Given this list of marker genes RAB21, GNRHR, ADCY7, PDK3, DIP2B, MARCHF7, RIOK2, WDR76, TPMT, ZNF624, MTPN (NCBI Gene Id 94351), TMEM47, LRCH2, MARK3, SETBP1, SDR16C5, PDE7A, SOCS2, RCOR3, EPM2AIP1, CDH13, AK2, PACRGL, C8orf33, TFAP2B, NPY2R, NECAP1, TMEM43, PPFIA2, RPA1, EIF4E, KAAG1, FOXR2, TTC5, TMEM131, ZBTB20, ODAPH, BRWD3, MARCHF9, LIMS1, SMIM20, SMOC2, SCAF4, HS3ST3B1, SACS, XRCC2, ASPH, DYNC1I1, LRATD1, NR2C2, BBS12, PELI1, MKLN1, IL11, KICS2, FAHD1, KIAA1958, PAX8, EGR4, ZKSCAN1, MEI4, NUP54, ZMYM2, ZMYND11, CEP70, XKR6, SGIP1, NKAPD1, DIP2C, ERICH2, VPS45, CCNT2, SLC17A8, NR1D2, COL19A1, SUMO1, CRIM1, FAM3C, SAYSD1, PARP4, GBP1, CCER1, GOLGA7, ADD3, ANK3, AK5, NTRK1, GNPNAT1, DIO2, GABPB1, CARMIL1, ZNF592, FGD4, NLGN1, ENY2, SPICE1, SHANK2, ACTR3, UACA, ERCC6, YTHDF3, PTPRZ1, SATB1, RASSF6, SRSF1, BICRAL, CD47, SLC6A6, TMEM87B, ZEB2, TUBGCP3, TOR1AIP2, IBTK, TMEM273, PGM3, TRMT9B, HMGCS2, MARCHF5, RFX4, EPC1, CCDC34, RANBP3L, DPYD, PIKFYVE, HECW2, PLPBP, MTDH, CCDC14, CXXC4, MPI, PDE4D, ELK4, ELF2, ZNF503, POC5, ZNF33B, CACNA2D1, E2F3, CA13, FMNL2, BCAT1, STX16, MYBL1, PFN2, FSTL5 (follistatin like 5), CRHBP, PLA2G2A, MMP7, CENPI, IRX2-DT, MTPAP, PANK2, NUP35, NEUROD6, MCMDC2, AKAP12, HNRNPF, HMCN1, PSEN1, ZC3H6, GAB1, NIFK, TEAD1, CDCA7L, RPRD1B, TMEM276-ZFTRAF1, NAP1L5, TMPRSS12, STAU2, PALS1, PTPN3, TSPAN7, C1orf141, SLC35A3, ZNF33A, ZDHHC2, METAP1D, TRIM44, GSPT1, KRT37, PICALM, INO80D, COL4A4, PLCXD3, BVES, NAALADL2, SLC44A1, AJAP1, ADM, LMO4, TAX1BP1, here is a description of the gene set: species: Homo sapiens Genes predicted to be targets of miRBase v22 microRNA hsa-miR-302f in miRDB v6.0 with MirTarget v4 prediction scores > 80 (high confidence targets). from publication Chen Y, Wang X (PMID 31504780) Human Gene Set: MIR302F